The following is a description of a gene set: studied in species Homo sapiens Any process that activates or increases the frequency, rate or extent of the directed movement of substances between the nucleus and the cytoplasm. Human Gene Set: GOBP_POSITIVE_REGULATION_OF_NUCLEOCYTOPLASMIC_TRANSPORT, and this is the list of marker genes: IL1B (interleukin 1 beta), RBM22, CTDSPL2, CDH1, EFCAB7, KHDRBS1, EP300, SMAD3, HCLS1, IFNG (interferon gamma), EMD, RAN, PRKACA, CPSF6, MAPK14 (mitogen-activated protein kinase 14), CHP2, ECT2, TARDBP, PRKCD, PIK3R1, SIRT6, JAK2, FLNA, ANP32B, DHX9, SHH, YWHAE, LEP, GSK3B, MDM2, RAPGEF3, PPM1A, RIOK2, SMO, TGFB1, IPO5, UBR5, PSEN1, CDK1 (cyclin dependent kinase 1), DMAP1, NCBP2, SFN, PRKD1, NEDD4, TRIM28, HSP90AA1, CAMK1, ZC3H12A, PRP4K, NRDE2, HDAC3 (NCBI Gene Id 8841), PIK3R2, JUP, ZIC1, MAVS, XPO4, XBP1, HYAL2, ZPR1, TPR, GLI3, GAS6, BAG3